The following is a description of a gene set: Any process that decreases the rate, frequency, or extent of blood vessel formation when new vessels emerge from the proliferation of pre-existing blood vessels and contribute to the series of events that restore integrity to damaged vasculature. Mouse Gene Set: GOBP_NEGATIVE_REGULATION_OF_VASCULAR_WOUND_HEALING species: Mus musculus, and this is the list of marker genes: Alox5 (arachidonate 5-lipoxygenase), Slc12a2, Tnf, Tafa5, Serpine1